Given this list of marker genes CIC, TMEM106B, SQSTM1, GRN, PSEN1, NONO, CHMP2B, MAPT, TBK1, USP7, CHCHD10, VCP, TREM2, TACO1, NOTCH3 (notch receptor 3), FUS, NPC2, TTPA, TARDBP, PRNP, here is a description of the gene set: species: Homo sapiens Human Gene Set: HP_PERSEVERATIVE_THOUGHT Perseverative thought The repetitive production of the same response to different commands.